The following is a description of a gene set: studied in species Homo sapiens An abnormal forward-flexed posture e.g. forward flexion of the spine, which is noticeable when standing or walking but disappears when lying down. It is becoming an increasingly recognized feature of Parkinson's disease and dystonic disorders. Camptocormia Human Gene Set: HP_CAMPTOCORMIA, and this is the list of marker genes: SMCHD1, SLC30A9, FRG1, PHKA1, COQ2 (coenzyme Q2, polyprenyltransferase), DUX4L1, DUX4, DNMT3B, ADCY5, PHKG1